Given this list of marker genes ITGA7, SEMA3D, SH3TC2, WNT1, C4A, ABCC9, ACTN2, KIF5A, OPA1 (NCBI Gene Id 4976), CHRNA2, PARN, NEK1, TAF1A (TATA-box binding protein associated factor, RNA polymerase I subunit A), GABBR1, MT-TL1, LDLR, HABP2, STAR, STN1, ENPP1, MPV17, ISCU, NAA80, NPM1, ALDOA, DKK1, POLG2, TGFB1, ACTA1, GATA4 (NCBI Gene Id 2626), EPB42, POLD1, SULT2B1, COL9A1, ANTXR1, ZEB1, TRIO, TGFBR2, GATA2, DDRGK1, CDKN2B, EPOR, JMJD1C, GDNF, ALMS1, CCND1, LRIG2, APOB, DGUOK, PHKG1, FCGR3B, EPB41, NIPAL4, HAVCR2, SLC20A2, TBL1XR1, TGFBI, VPS37D, MAN2B1, FUS, GCSH, SLC22A12, SDHAF2, CFH, KCNH2, NOD2, KIF11, HMGCL, NRAS, CFAP410, DLST, MT-TS2, SPTB, GIMAP5, BCS1L, ALAD, GNA11, CBL, LDLRAP1, SFRP4, EWSR1, TNFRSF13B, TP63, DNAJB11, PDGFB, HS6ST2, CAVIN1, SYNJ1, PROKR2, PXK, PYGL, MFAP5, C4B, TGM1, PLEC, ANTXR2, SCO2, CTLA4, LMNA, PSMB8, ATP11A, PKHD1, KIF7 (NCBI Gene Id 46), DCTN1, ECE1, CITED2, COL4A6, CD46, SCN4B, PHEX, TNFSF15, MAPK8IP3, MCM6, BAP1, GOSR2, KCNQ1, SERPINF2, SCN8A, ALDH18A1, STX1A, GK, XPC, TNPO3, RASA1, CDKN1A, TCIRG1, MAT1A (methionine adenosyltransferase 1A), SALL1, CD55, NEB, HEXB, SOD1, TSPOAP1, LEMD2, LZTR1, IL12A, COMT, PRKAG2 (protein kinase AMP-activated non-catalytic subunit gamma 2), PTPN3, CDKN2C, MMP13, SELENBP1, ADNP, CDH23, BAG5, DLEC1, MT-ND4, MMEL1, TNIP1, TNFSF12, IGLL1, ABCB4, TBX19, COL12A1, MLYCD, MSH2, IMPDH2 (NCBI Gene Id 3615), RSRC1, CHRNA4, PODXL, WAS, GCDH (glutaryl-CoA dehydrogenase), FCGR2B, DTNA, NOTCH3, HBA2, SMAD3, ARVCF, ERAP1, MYH11, ORAI1, SPTAN1, ADAMTS19, STEAP3, PDGFRB, CACNA1C, PGM1, PRDM16, MYH6, PIGT, DMP1, RYR1, KL (NCBI Gene Id 9365), ASAH1, IDUA, MUTYH, SLC4A3, IRF2BP2, MYH7, SPIB, TNFRSF13C, CASK, ATRX, KCNJ2 (potassium inwardly rectifying channel subfamily J member 2), PKD1 (NCBI Gene Id 5310), HNF4A, CASR, LEMD3, CACNA1H, SI, ANKRD1, PORCN, GATA5, RTEL1, MMP1, IRF4, MT-ATP8, AP5Z1, PIEZO1 (NCBI Gene Id 9780), ALB, PIGF, ADA2, MAP3K20, CCNF, COA3, ATPAF2, EIF2AK4, CFAP43, POLR3A, BCOR, WIPF1 (WAS/WASL interacting protein family member 1), IGF2, CCN2, SLC39A7, GANAB, PLAG1, AEBP1, CAV3, SUFU, GLE1, RNU4-2, MT-TQ (NCBI Gene Id 4572), FLNC, APOL1, MAPK1, SNX10, SCN1B, MYBPC3, FDX2, CDC73, SPI1, ACSF3, HMGCR, TRIM32, MTHFD1, MT-TK, ARNT2, ALDH4A1, ERBB2, MT-ND6, SLC18A3, PEX11B, DSP, POMP, BLK, EMD, IFNGR1, SLC39A14, RETREG1, ALS2, HLA-DPB1, TEK, VSX1, BAG3, KCNA5, PLCG2, KIT, DIS3L2, SPINK1, HTRA1, RSPH9, PMS2, BCL6, HPS6, ERCC2, MYL4, PRKG1, TNFRSF11A, FHL1, PLN (NCBI Gene Id 5350), COL9A2 (collagen type IX alpha 2 chain), SLC25A42, SCN9A, PMS1, MAFB, BLNK, FLT1, KCNE1, PAX2, MFN2, KCNE2, TLR4, IVD, GALC, DNMT3B, RTN2, STX16, ROS1, CFTR, DMPK, MYH3, PGK1, REST, RAPSN, LRP5 (LDL receptor related protein 5), PALLD (NCBI Gene Id 51653), GTF2I, GRHL2, NEXMIF, BRAF, ETS1, BAZ1B, TBX1, ERCC4, PREPL, MTTP, GBA2, OTX2, LAMP2, TNFAIP3, KCNC3, MYL2, PUS1, SLC26A2, CDH2, PIEZO2, HMBS, UNC93B1, LDB3, AUH, SYNE1, MAX, WWOX, HRAS, ABCA12, SLC4A1, TBC1D8B, ANKH, TRPA1, KRT6B, SLC12A3 (solute carrier family 12 member 3), RHAG, ATXN10, MMP2, EIF4H, BIRC3, CYP7B1, APRT, TNNC1, CHST3, MAP2K1, MINPP1, EYA4, PTPN22, CD244, RAD21 (RAD21 cohesin complex component), COL10A1, TRIM28, SEMA4D, TK2, HESX1, SLC3A1, PRNP, KIF1B, STAT3, FGF13, ANO5, NOP56, VDR, DNASE1L3, ARHGAP24, NEXN, IL12B, HNRNPA1, MLH1, TBX20 (NCBI Gene Id 57057), ALOX12B, KCNJ3, NTRK1, IL12RB1 (NCBI Gene Id 3594), ABCA3, PITX2, SMAD2, LACC1, IDH1, PSTPIP1, FRG1, CALM3, CCR1, COL4A3, IL10, CIITA, FIG4, PLP1, G6PD, GLI2, JRK, ATP8B1, TGFBR1, DNMT3A, FLVCR1, CRLF1, UFD1, FARSB, RACGAP1, COL5A1, BCL2, POMGNT1, BSCL2, TRAPPC2, C1QBP, MYLK2, SFTPA1, TIMM50, HSPD1, HBB, GJC2, MPL, MOCOS, MYT1L, BANK1, TNFRSF1A, GTF2IRD1, RARA (retinoic acid receptor alpha), DUX4L1, LAMA4, HACE1 (NCBI Gene Id 57531), LBR, STUB1, ASPRV1, TXNRD2, DACT1, KPNA3, NTN1, RBCK1, IL36RN, TBXT, ARHGDIA, TGFB2, SPTA1, COMP, ERLIN1, KLRC4, HEY2, LRP1, SLC34A3, IL2RB, NFKB1, IRF5, DPH5, FKBP6, BVES, HFE, SLC25A32, SPAST, TARDBP, SERPING1, PKDCC, NF2, ERCC5, OTULIN, MRPS2, GPD1L, CRH, JAG1, PYGM, PHIP, PTH1R, LIPN, ERLIN2, HPSE2, ZFYVE26, MED12, SLC44A1, HBG2, ATXN2, GLT8D1 (NCBI Gene Id 91870), SLC34A1, UQCRH, RSPH4A, PROC, ALG10B, NAGS, MT-ND5, HPGD, MAGI2, TMPO, SEC24C, SOX2, PNPLA2, STAT1, PABPN1, SCN5A, HAND2, DSC2, ARX, ARSB, POLR3B (RNA polymerase III subunit B), BRCA1, MDH2, MESP2, BUD23, LMNB2, TREM2, ZNF687, SBF1, GNAS, PTEN, UFSP2, IGHG1 (immunoglobulin heavy constant gamma 1 (G1m marker)), ACTA2, TNNT2, SURF1, CPT1C, GTF2IRD2, RET, COG5, PFN1, MATR3, HLA-DQB1, FMO3, ELF4, MYO1E, AGBL1, B2M, MEOX1, SFTPA2, IKZF1, NPPA, ALAS2 (5'-aminolevulinate synthase 2), SMPD1, TOP3A, FITM2, NAGLU, RYR2, SQSTM1, LMX1B, LIMK1 (LIM domain kinase 1), FHOD3, PPCS, MECP2, SACS (NCBI Gene Id 26278), WNT3A, RUNX1, SDHD, VCL, ATP5F1E, MT-TE, THSD4, AGK, GNAQ, HLA-DRB1 (NCBI Gene Id 730415), UBA1, GATM, SLC25A26, CHCHD10, VHL, IRAK1, CHMP2B, EIF2AK2, ATP13A3, CARS2, GNE, NEFH, SLC2A1, SEMA3C, LIN28B, NUP93 (nucleoporin 93), THRB, MYLK, PHKA2, RNF170, ATXN3, GYS1, CR2, DUX4 (double homeobox 4), STAT4, SLC2A9, MET, HLA-DPA1, HLA-DQA1, CEBPE, DLL3, COL1A2, NUP205, HBG1, PRSS1, CRYAB, GCH1, CALM1, ACAD9, PRORP, CRKL, TBX18, TSPYL1, IGKC, CLPB, SLC40A1, SIN3A, SLC4A11, PIK3CG, GYPC, ZC4H2, SCARB2, CABP4, COL1A1, KIF23, GATAD1, ATP5MK, HELLPAR, MC2R, FOXE1, CPA1, MST1, NAXE, FAS, TMEM127, MTMR14, ABCD1, TYROBP, POMT1, TNFSF4, ATP2A1, TMEM126B, KRAS, COL14A1, JAK2, ALK, ACTG2, PRKRA, ACBD6, NKX2-5, MSH6, TLL1, ICOS, ENO3, ACAT1 (acetyl-CoA acetyltransferase 1), DNAJB6, STAT6, EHHADH, MT-ATP6, KMT2B, SELENON, LPL, TLR7, ASXL1, GNPTAB, REEP2, TRPC6, MS4A1, TNXB, ANKFY1, GET3, NR4A2, SLC32A1 (solute carrier family 32 member 1), NOTCH2NLC, CYSLTR2, ABCG8, LMNB1, LIG3 (NCBI Gene Id 3980), PHKG2, CACNA2D1, DES, METTL27, SERPINA6, RBM20, MYL3, COL5A2, AP2S1 (NCBI Gene Id 9161), MT-CYB, FHL2, DMD, IL12A-AS1, NPHS2, MLX, NFKB2, TRMT5, CPT2, SAA1, NUP155, DPM3, ZBTB16, OBSCN, DPP9 (NCBI Gene Id 91039), DOLK, COQ8A, NUMA1, SDHA, POT1, BMPR1A, HSPG2, ITGAM, BMP2, PRSS2, PHOX2B (NCBI Gene Id 8929), POLR3GL, CSRP3, SF3B1, TRAPPC11, COL6A1, RIN2, CLIP2, IFT57, BICC1 (BicC family RNA binding protein 1), CLCF1, CLCN5, HARS1, MVK, NAB2, MAT2A, AHDC1, MSTO1, COL4A5, PGAM2, CAT, GNPTG, CASQ2, SMARCB1, NKX2-1, ERBB3, NDUFS4, GAA, BICD2, F12, TRHR, SGCD, CNBP, DDHD2 (DDHD domain containing 2), CALR, TBX6, TRAF7, C1R, RABL3, GDF3, IGHM, RB1, ATP5F1A, RRM2B, KRT16, EMP2, MYD88, KLHL41, NUP133, C1S, OPTN, PTPRO, OPA3, ATP7B (NCBI Gene Id 540), MGME1, POU6F2, GALNT2 (NCBI Gene Id 2590), TRAF3, FN1, AAGAB, PPA2, PON3, MLIP, LRP6, TCAP, CPLX1, TYMP, ALG9, SCNN1A, SMO, LPIN2, VANGL2, ELN, PALB2, NUP37, PPP2R5D, NR1H4, RNASEH1, IDH2, HIRA, PCSK9, COQ6, AMPD3, PIGA, MT-CO2, YY1, MEFV, STING1, XPA, FRMD5, H19, CD79B, UBE2L3, CD28, TAFAZZIN, ABCC2, SLC26A4, MEF2A, DNAL4, GMPPB, CEL, COL17A1, NR3C1, GABRG2, DNAJC30 (DnaJ heat shock protein family (Hsp40) member C30), LDHA, CD79A (CD79a molecule), DNAJC6, HOGA1, OPLAH, MMADHC, GNAI2, GABRB3, ZMYM3, FH, COL2A1, SEC63, COL11A1, CHST6, PDGFRA, GJA5, CLCN1, TFR2, HS3ST6, ACADVL, CLDN16, SCN3B, ACVR1, ZFTA, LYN, CAPN3, DSG2, TNNI3, RPS20, CDKL5, GCGR, F5, HADHA, ANG, IL1RN, PHKB (phosphorylase kinase regulatory subunit beta), ATXN8OS, HACD1, OTC, AGXT, NEFL, KRT14, DNM2, CLCN7, ATL1, SCN10A, NOS1 (nitric oxide synthase 1), CDKN1B, MT-TF, CYP2R1, NGLY1, PSEN1, IL21, LHX4, NOTCH2, MORC2, ABCG5, BCL11A, INSR, BTNL2, FKRP, SNTA1, RAD51, MSMO1, PON1, PTPN6, BMP4, ATP13A2, FARS2, MYC, MYCN, CARMIL2, NPRL3, ANKRD55, NKX3-2, GPR101, IGHG2, ANK2, POLG, PAX8, FLAD1, SRSF2, ZFX, DYSF, FKTN, FSHR, PDCD1, BIN1, ANK1, CRELD1, UBAP1, ERCC3, FOXA2, DSTYK, CPT1A, PTPN2, PML, YARS2, HYAL1, LRIF1, MNX1, ATM, FERMT3, ACTN4, RFC2, CACNA1S, CTSK, COL7A1, EPAS1 (endothelial PAS domain protein 1), LMO1, DDIT3, GLA, KCNJ5, PRTN3, KIAA0319L, BMP6, EDN3, MUC5B, TBCD, MT-TH, UBAC2 (UBA domain containing 2), TICAM1, DAAM2, TERT, HADHB, ASPN, COX6B1, NFKBIL1, SMAD4, VEZF1 (NCBI Gene Id 7716), NPRL2, SYNE2, ABCC6, C1QB, TCF4, TBC1D24, TMEM43, GHSR, CCN6, UNC45B, FAM13A, DAO, MYF6, DNAJC19, CD19, SPTLC2, CACNA1G, TP53, PIK3CA, PRDM5, CAV1, KRT5, PLAAT3, DNA2, VAPB, TONSL, CRPPA, COL3A1 (NCBI Gene Id 1281), INF2, SLC2A10 (NCBI Gene Id 81031), ACADM, IL2RA, IL23R, COQ2 (coenzyme Q2, polyprenyltransferase), GPC3, CORIN, VANGL1, MALT1, CD81, SAT1, TMEM270, ANXA11, DDB2, TLR3, SEPTIN9, SLC26A1, CYP17A1, PSMB4, PRPH, NNT, BNC2 (basonuclin zinc finger protein 2), CTNS, CD247, EDNRB, AMPD1, TNFRSF11B, FGF23, KRT6A, STOX1, DCC, CAP2, SEMA4A, CFI, GBE1, ARSA, EXT1, ACP5, TH, MIF, COPA, TRANK1, IL6, NSDHL, CHRNB2, ENSG00000288330, GAPVD1, MT-TN, SPG11, TECRL, HEPHL1, SLC25A11, JAZF1, VCP, RREB1, ISL1, GUF1, KRT17, SMARCE1, LHX3, TAF15, ALOXE3, DNMT1, KLF1, GP1BB, TSHR, DSE, PNPLA8, TRPV6, ESR1, THPO, NRTN, GNA14 (NCBI Gene Id 9630), SPG7, LPIN1, NUP160, TBL2, FARSA, SCNN1B, POLE, GNB2, SCN1A, TET2, LRP12, PPOX, SOX3, KCNE3, HBA1 (NCBI Gene Id 3039), DNASE1, COQ8B, TSHB, ASCC3, MLXIPL, ZNRF3, FGFR3, TPM3, CHEK2, CLCNKB, HINT1, UBR7, POU2AF1, SPTLC1, FGFR1, CHST11, SLC9A6, CRB2, TNFRSF1B, MITF, IL1R1, WASHC5, SREBF1 (NCBI Gene Id 6720), SRP19, COL13A1, FOXE3, SLC22A4, TTR, AKT1, STAT5B, PIK3R1, NIPA1, IGHMBP2, SIGMAR1, CYB5A, TWNK, FIP1L1, IVNS1ABP, ATP5F1D, FMR1, UNC13A, APOE, KLHL24, DBH, RNU4ATAC, ACTC1, NLRP3, GBA1 (NCBI Gene Id 82008), KBTBD13, NDUFAF6, JPH2, NKX2-6, FTL, COPB1, SDR9C7, PROP1, SDHB, STK11 (NCBI Gene Id 6794), TGFB3, HNRNPA2B1, P4HA2, GPR35 (NCBI Gene Id 2859), ATL3, IFT140, PROS1, KY, PRDM8, ABCB11, PRKAR1A, CDKN1C, LMOD2, JUP, MATN3, NUP85, RNF6, FILIP1, GFAP, TNFSF11, PTPN11, FUZ, MYOT, SFTPC, SCN2B, ATP7A, MDM4, SOST, TBP, GJB6, CARD8, CYP27B1, GABRA1, MT-CO1, NGF, CYP19A1, MYPN, SPTBN1, NCF4, POU1F1, HGD (homogentisate 1,2-dioxygenase), RPL3L, HPS1, UNC45A, NR0B1, PON2, ABL1, EPCAM, CPOX, PLCE1, SHQ1, DGAT1, COL11A2, ZMYM2, ZNF469, KCNN4, CCL2, GJB2, AKAP9, SDHC, NABP1, TBK1, ELANE, PKD2, NCF1, MT-ND1, VPS13C (vacuolar protein sorting 13 homolog C), ZEB2, TRIP13, GLDC, TREX1, CASQ1, SCN4A, AP1S3, PLEKHM1, PPARGC1A, TRPV4, DMGDH, LRRC8A, CD2AP, SMCHD1, HMGA2, FA2H, SLC34A2 (solute carrier family 34 member 2), TREH, ALG5, RAF1, CALM2, ANLN, ABCA1, COQ7, EXT2 (NCBI Gene Id 2132), PRKCSH, TRDN (NCBI Gene Id 10345), MIEF2, SLC1A4, PHKA1, COL9A3, SPP1, FBN1, PSAP, KCNT1 (potassium sodium-activated channel subfamily T member 1), SLCO2A1, GUCY2C, RNF168, APC, OVOL2, ARMC5, GGT1, PIGY, DPYSL5, GDF6, VWA1, NOS1AP, TRPS1, NF1, TBX5, PPARG, AIP, FLI1, MME, GFI1, TPM1, PANK2, GATA6, HLA-B, MRAP, CCDC78, UBQLN2, PNPT1, MMUT, SCN11A, GCK, NUP107, TACSTD2 (NCBI Gene Id 4070), BCL10, MYO1H, STIM1, CTRC, CYP4F22, TRPM4, TCF3, MYOZ2, BRCA2, ERBB4, TSC2, WT1, CAPN1, MT-CO3, MT-TW, HPDL, CTNNB1, NLRC4, LOX, CDKN2A, WRN, SH2B3, MEN1, COL8A2, IL18BP, PSEN2, DEPDC5, PMP22, CCR6, NPHS1, BCR, ENG, SLC25A4, ZMPSTE24 (NCBI Gene Id 10269), HCN4, F8, SLC25A13, BTK, SCNN1G, RIPK1, PFKM (NCBI Gene Id 5215), POLR2A, TTN, GRM1, PKP2, SOX10, TPM2, TERC, KCND3, SYK, SLC18A2, NLRP12, FOXP1, TSC1, ALDOB, DPP6, SVIL, DNM1L, here is a description of the gene set: Constitutional symptom Human Gene Set: HP_CONSTITUTIONAL_SYMPTOM studied in species Homo sapiens A symptom or manifestation indicating a systemic or general effect of a disease and that may affect the general well-being or status of an individual.